Given this list of marker genes MUSK, POU4F2, ROR1, EPHA2, EPHB6, NTRK2, EPHA7, CD4, PTPRG, EPHA4, EPHB1, TSPAN2, KIT, BDKRB2, CD8B, CYP1B1, NRTN, EPHB2, DDR2, PDGFRA, CD8A, ERBB2, TEK, EPHB4, EDN2, EPHB3, INSR, FLT1, KDR, DOK1, PDGFRB, PAX6, here is a description of the gene set: Human Gene Set: MODULE_80 Genes in the cancer module 80. species: Homo sapiens